Given this list of marker genes INHBA, PPBP, S100A6, PTN, EDN2, JAG1, PDGFA, CRIPTO, PDGFB, MDK, FGF11, FGF1, CXCL8, DKK1, IGF2, NRG2, CSF1, TNFRSF11B, LTB, CXCL1, TGFB3 (NCBI Gene Id 7043), IL6, IL11, GRP, FGF2, CXCL12 (C-X-C motif chemokine ligand 12), BMP4, IL24, TNFSF9, CSF3, SCGB1A1, LIF, OGN, TNFSF13, BMP7, IGF1, IL9, EREG, EGF, BMP1, IFNA5, NRG1, TGFA, MIA, CCN3, BMP2, NTF3, VEGFC, AREG, IL17A, FGF12, IFNG, IL15, OSM, TNFSF10, NAMPT, HBEGF, TGFB2, FGF7, FGF6, PGLYRP1, here is a description of the gene set: Human Gene Set: MODULE_433 Cytokines and GFs. species: Homo sapiens